The following is a description of a gene set: studied in species Homo sapiens Marker genes curated from the annotated cluster as represented in the Descartes Human Gene Expression During Development database. Human Gene Set: DESCARTES_FETAL_PANCREAS_LYMPHATIC_ENDOTHELIAL_CELLS from publication Cao J, O'Day DR, Pliner HA, Kingsley PD, Deng M, Daza RM, Zager MA, Aldinger KA, Blecher-Gonen R, Zhang F, Spielmann M, Palis J, Doherty D, Steemers FJ, Glass IA, Trapnell C, Shendure J (PMID 33184181) The gene expression program underlying the specification of human cell types is of fundamental interest. The study authors generated human cell atlases of gene expression and chromatin accessibility in fetal tissues. For gene expression, the study authors applied three-level combinatorial indexing to >110 samples representing 15 organs, ultimately profiling ~4 million single cells. The study authors leveraged the literature and other atlases to identify and annotate hundreds of cell types and subtypes, both within and across tissues. Our analyses focused on organ-specific specializations of broadly distributed cell types (such as blood, endothelial, and epithelial), sites of fetal erythropoiesis (which notably included the adrenal gland), and integration with mouse developmental atlases (such as conserved specification of blood cells). These data represent a rich resource for the exploration of in vivo human gene expression in diverse tissues and cell types., and this is the list of marker genes: ELMOD1, CACNA2D1-AS1, LINC01252, CCL20, LNCEGFL7OS, C20orf204, PDF, GABRP (NCBI Gene Id 2568), STAB2, IRX3, DDX59-AS1, ANO9, IL5RA (interleukin 5 receptor subunit alpha), RPS15AP10, PGM5, BMP6, LINC00636, TNFRSF9, CXCL5, TRIM54, ENSG00000223786, ENTREP1, MPP7, TRMT9B, ENSG00000260733, KRT18P55, HOXD10, RASSF9, RPAP3-DT, TLL1, TBX1, CTHRC1, NFATC1, ENSG00000255240, PARD6G, NRG3, GPR182, VPS26BP1, DHODH, LINC02147, KCNJ2-AS1, GNA14-AS1, BMPER, TNFRSF11A, RALGAPA2, MYCBPAP, STON2, FLNC-AS1, RSF1-IT1, NTS, PTGS2, CEMIP, F8, GPM6A, ABCA4, RPS26P43, RNU1-109P, LRRC69, P3H2-AS1, INO80C (INO80 complex subunit C), SLC30A3, TNFAIP8L3, ADD3-AS1, FOXC2, TFPI, RPS7P4, MMRN1, FZD10